The following is a description of a gene set: Human Gene Set: REACTOME_NEUROTRANSMITTER_RECEPTORS_AND_POSTSYNAPTIC_SIGNAL_TRANSMISSION Neurotransmitter receptors and postsynaptic signal transmission studied in species Homo sapiens, and this is the list of marker genes: GABBR2, TUBB1, KCNJ6, AP2A1, HTR3D, CHRNB3, GLRA2, PRKAR1A, GABRR1, GNG11, GABRQ, GNB1, RAC1, NEFL, PLCB3, CHRNE, KCNJ2, GRIK5, GRIK2, GLRB, ADCY8, GNG13, GNG10, AP2S1, GRIA3, GRIN2D, GRIN2A, GRIP2, KCNJ9, KCNJ12, CAMK2B, KCNJ4, TUBAL3, KCNJ16, NPTN, PRKACB, PPM1E, PRKAG1, CHRND, ARHGEF9, TUBB3, EPB41L1, GNG5, RPS6KA2 (NCBI Gene Id 6196), GABRA5, CHRNA7, CAMKK2, ADCY3, TUBB6, GNAL, PRKAA1, LIN7B, HTR3A, AP2M1, CHRNA5, CHRNA4, ADCY6, TUBA1B (NCBI Gene Id 88851), PRKAG2, PRKACG, PRKAR1B, CASK, CHRNG, TUBA3D, RPS6KA3, GRIK3, GRIN3A, KRAS, AP2B1, GABRB2, TUBA4A, ARHGEF7, TUBA8, CREB1, PRKACA, CAMK1 (calcium/calmodulin dependent protein kinase I), KCNJ5, PRKCA, CACNG2, PRKCB, GLRA3, RASGRF2, PRKAB2, PRKAG3, GABRG3, HTR3C, HTR3E, ADCY7, CAMK2D, GNB4, ERBB4, ADCY5, GNG4, TUBA3C, TUBB4A, CAMK2A, PRKAB1, GABRB3, TUBB8, PRKX, ACTN2, CAMK4, GNB5, GRIA4, PICK1, GNG2, TUBB2B, KIF17, GABRA6, GNAI3, AKAP5, RASGRF1, GABBR1, CALM1, GNAI2, KCNJ15, KCNJ10, CAMK2G, RPS6KA1, MDM2, GABRB1, NRG1, MAPT, GNGT1, CHRNA3, APBA1, GRIA1, GNG12, TUBA1C (tubulin alpha 1c), GABRA1, GABRR3, AP2A2, CACNG8, GABRA2, CHRNA1, CHRNA2 (NCBI Gene Id 1135), HTR3B, NCALD, GRIA2, GRIK4, GNAI1, GNG8, PRKAA2, TUBA1A, PPM1F, CHRNA6, HRAS, GRIP1, DLG3 (discs large MAGUK scaffold protein 3), TSPAN7, GNAT3, ADCY4, PLCB2, NBEA, ADCY1, CHRNA9, TUBB2A, CACNG4, PLCB1 (phospholipase C beta 1), GNG3, LIN7A, TUBA4B, DLG4, GRIN3B, DLG1, KCNJ3, LIN7C, GNB3, TUBA3E, PRKCG, GRIN2C, CACNG3, GRIN2B, GABRA4 (NCBI Gene Id 2557), PDPK1, PRKAR2A, CHRNB4, MYO6, GRIN1, NRAS, ADCY2, CAMKK1 (calcium/calmodulin dependent protein kinase kinase 1), GIT1, GABRA3, SRC, RPS6KA6, GNGT2, MAPK1, TUBB8B, GNG7, TUBB4B, PRKAR2B, ADCY9, GNB2, GLRA1, CHRNB2, MAPK3, NSF, DLG2, LRRC7, GRIK1 (NCBI Gene Id 2897), KPNA2, NRGN, GABRR2, GABRG2